Given this list of marker genes Hadha, here is a description of the gene set: electronically inferred by orthology from the curated human pathway Reactome Pathway: Beta oxidation of lauroyl-CoA to decanoyl-CoA-CoA part of: mitochondrial fatty acid beta-oxidation of saturated fatty acids This event has been computationally inferred from an event that has been demonstrated in another species.<p>The inference is based on the homology mapping from PANTHER. Briefly, reactions for which all involved PhysicalEntities (in input, output and catalyst) have a mapped orthologue/paralogue (for complexes at least 75% of components must have a mapping) are inferred to the other species. studied in species Mus musculus